The following is a description of a gene set: Binding to lamin; any of a group of intermediate-filament proteins that form the fibrous matrix on the inner surface of the nuclear envelope. studied in species Mus musculus Mouse Gene Set: GOMF_LAMIN_BINDING, and this is the list of marker genes: Dmd, Bnip3l, Sun1, Bnip3l-ps, Pkp1, Prnp, Ppp1cc, Plcb1, Hnrnpk, Tmem201, Narf, Akap8l, Syne1, Tor1aip1, Mlip, Ppp4c, Ifi27, Sun2